The following is a description of a gene set: A blood vessel cell type detected with low abundance. It contained conventional markers PLVAP, CLDN5, and CD93. species: Homo sapiens The transformation of benign lesions to malignant tumours is a crucial aspect of understanding chondrosarcomas, which are malignant cartilage tumours that could develop from benign chondroid lesions. However, the process of malignant transformation for chondroid lesions remains poorly understood, and no reliable markers are available to aid clinical decision-making. To address this issue, we conducted a study analysing 11 primary cartilage tumours and controls using single-cell RNA sequencing. By creating a single-cell atlas, we were able to identify the role of endoplasmic reticulum (ER) stress in the malignant transformation of conventional central chondrosarcomas (CCCS). Our research revealed that lower levels of ER stress promote chondrosarcoma growth in a patient-derived xenograft mouse model, while intensive ER stress reduces primary chondrosarcoma cell viability. Furthermore, we discovered that the NF-?B pathway alleviates ER stress-induced apoptosis during chondrosarcoma progression. Our single-cell signatures and large public data support the use of key ER stress regulators, such as DNA Damage Inducible Transcript 3 (DDIT3; also known as CHOP), as malignant markers for overall patient survival. Ultimately, our study highlights the significant role that ER stress plays in the malignant transformation of cartilaginous tumours and provides a valuable resource for future diagnostic markers and therapeutic strategies. from publication Su Z, Ho JWK, Yau RCH, Lam YL, Shek TWH, Yeung MCF, Chen H, Oreffo ROC, Cheah KSE, Cheung KSC (PMID 38267611) Human Gene Set: SU_HO_CONV_CENT_CHONDROSARCOMA_STROMAL_C6_ENDOTHELIAL_CELL, and this is the list of marker genes: SLC27A3, DOCK6, MAP3K11, NRP2, GARRE1, TSPAN15, PTPRN2, INSR, SNRK, HEG1, NQO1, SOX17, PLAU, STMN1, CEMIP2, APP, CYTH1, FRMD8, GIMAP1, SEC14L1, ROBO4, INHBB, FLT1, CLEC14A, IPO11, ITGA5, SLC12A2, PLXNA2 (plexin A2), LGALS9, CAVIN2, TIE1, PTPRB, PON2, CXCR4, RAMP3, STAB1, FLI1, NFIB, PLPP3, A4GALT, VWF, HCLS1, ENTPD1, RAB13, SELENON, PCAT19, PLEKHO2, DLL4, CA2, EGFL7, MGST2, HDAC1, PLK2, GNAI2, PODXL, TLNRD1, THBD, FABP4, JUP, YES1, TSPAN14, FSCN1, S1PR1, PECAM1, RHOJ, LIMS2, NECTIN2, SIGIRR, UBALD2, ADCY4, NPDC1, ABI3, PRKCH, RBP7, FRMD4A, ITGA6, IL3RA, HERC1, CHD7, TMEM255B, MPZL2, ISG20, DIPK2B, EFCAB14, SAT1, NOTCH1, PLXND1, RAMP2, SULF2, ACVRL1, NOL4L, ADAMTS9, WDR1, KANK3, CYYR1, TTC28, MALL, PNP, CXCL12, DUSP6, ARL4A, GIMAP4, DOCK9, LMO2, GRB10, PROCR, HYAL2, NOTCH4, ADGRL4, PCDH17, HSPA12B, TCF4, PALMD, MYL12A (NCBI Gene Id 10627), LYL1, SPRY4, PLAT, TPM3, CLDN5, LXN, VASH1, SVIP, SOX18, CARD8, COX6C, APLP2, N4BP3, CD34, SHANK3, HHEX, TBCD, SEMA3F, SMAGP, TM4SF1, HSPG2, PLVAP, RASGRP3, TEAD4, MTSS1, HOMER3, CDH5, GABRD, LDB2, ATP2B4, TNFAIP8L1, PPM1F, GNG2, FZD4 (NCBI Gene Id 8322), GIMAP7, ECSCR, HMGB3, SCARF1, TRIOBP, MSN, CDH13, GRPEL2, PDGFB, CD93, APOLD1, TSHZ2, TCIM, SNCG, MARCKSL1, SEMA6B, FRMD4B, CALCRL, SH2D3C, STC1, FNBP1L, EPHB4, TM4SF18, PCDH12, BID, LYN, RAPGEF5, EMCN, ADGRG1, VWA1, HECW2, RNASE1, ADAMTS5, AFAP1L1, MAGI1, ICAM2, KDR, DNASE1L3, MYCT1 (MYC target 1), EFNB2, ADAM15, ELK3, MMRN2, PTPRE (NCBI Gene Id 5791)